Given this list of marker genes ITGB7, GUCY1A1, DPYSL2 (NCBI Gene Id 1808), PYGB, SORT1, ATP13A2, P3H2, MAL, CYBB, BORCS8-MEF2B, GYPC, CX3CR1, IL6R, MAFB, PKP2, MAF, GNAQ, VPREB3, BEX3, SRC, ABLIM1, GALNT10, TBC1D9, FGFR3, NTRK2, KLF4, FAM174B, TLR4, CCND2 (NCBI Gene Id 894), CCND1, CD99, NSD2, CXCL12, NUAK1, PXDN, KCNMB2, YBX3, here is a description of the gene set: Genes expressed in multiple myeloma (MM) patients carrying specific translocations involving the immunoglobulin heavy chain (IGH) locus at 14q32. species: Homo sapiens Human Gene Set: MATTIOLI_MULTIPLE_MYELOMA_WITH_14Q32_TRANSLOCATIONS Multiple myeloma (MM) is the most common form of plasma cell dyscrasia, characterized by a marked heterogeneity of genetic lesions and clinical course. It may develop from a premalignant condition (monoclonal gammopathy of undetermined significance, MGUS) or progress from intramedullary to extramedullary forms (plasma cell leukemia, PCL). To provide insights into the molecular characterization of plasma cell dyscrasias and to investigate the contribution of specific genetic lesions to the biological and clinical heterogeneity of MM, we analysed the gene expression profiles of plasma cells isolated from seven MGUS, 39 MM and six PCL patients by means of DNA microarrays. MMs resulted highly heterogeneous at transcriptional level, whereas the differential expression of genes mainly involved in DNA metabolism and proliferation distinguished MGUS from PCLs and the majority of MM cases. The clustering of MM patients was mainly driven by the presence of the most recurrent translocations involving the immunoglobulin heavy-chain locus. Distinct gene expression patterns have been found to be associated with different lesions: the overexpression of CCND2 and genes involved in cell adhesion pathways was observed in cases with deregulated MAF and MAFB, whereas genes upregulated in cases with the t(4;14) showed apoptosis-related functions. The peculiar finding in patients with the t(11;14) was the downregulation of the alpha-subunit of the IL-6 receptor. In addition, we identified a set of cancer germline antigens specifically expressed in a subgroup of MM patients characterized by an aggressive clinical evolution, a finding that could have implications for patient classification and immunotherapy. from publication Mattioli M, Agnelli L, Fabris S, Baldini L, Morabito F, Bicciato S, Verdelli D, Intini D, Nobili L, Cro L, Pruneri G, Callea V, Stelitano C, Maiolo AT, Lombardi L, Neri A (PMID 15735737)